Given this list of marker genes ETV1, IGFBPL1, SEZ6, ENO3, PIPOX, DBH, FNDC5, PTPRK, BAALC, SRRM4, DDC, NFASC, MFNG, THBS4, VWDE, IL17B, ASS1, here is a description of the gene set: MFNG+ DBH+ neuron from publication He P, Lim K, Sun D, Pett JP, Jeng Q, Polanski K, Dong Z, Bolt L, Richardson L, Mamanova L, Dabrowska M, Wilbrey-Clark A, Madissoon E, Tuong ZK, Dann E, Suo C, Goh I, Yoshida M, Nikolić MZ, Janes SM, He X, Barker RA, Teichmann SA, Marioni JC, Meyer KB, Rawlins EL (PMID 36493756) species: Homo sapiens Human Gene Set: HE_LIM_SUN_FETAL_LUNG_C7_MFNG_POS_DBH_POS_NEURON_CELL